Given this list of marker genes POLE (NCBI Gene Id 80252), IL6R, IL2RG, IGLL1, ATP6AP1, CARD11, IGKC, TOM1, IL6ST, MOGS (NCBI Gene Id 7841), CR2, LRBA, MAP3K14, RFXAP, PIK3CG, FAS, BACH2, TNFRSF11A, SEC61A1, POLD1, RNF168, PLCG2, BTK, SH3KBP1, EXTL3, ORAI1, TYMS, IVNS1ABP, RFX5, ADA, CTLA4, PTPRC, FASLG (Fas ligand), NFKB2, KNSTRN, ARHGEF1, CASP10, RAC2, NFKBIA, FNIP1, LAMTOR2, SPI1, BLNK, DOCK8, NAE1, DOCK11, CASP8, CD19, PIGT, PRIM1, BLM, STAT2, ADA2, SIK3, CNBP, WAS, IRF2BP2, LCK, TCN2, CD3E, LIG1, IGHG2, LYN, ICOS, TNFRSF13B (NCBI Gene Id 23495), CBLB, RAG2, IKBKG, TNFRSF13C, ALG12, PIK3CD, SASH3, PSMB10, TCF3, SYK, STIM1, CD79B (CD79b molecule), JAK3, ZBTB24, RAG1, here is a description of the gene set: Decreased circulating total IgM species: Homo sapiens An abnormally decreased level of immunoglobulin M (IgM) in blood. Human Gene Set: HP_DECREASED_CIRCULATING_TOTAL_IGM